Given this list of marker genes Uqcrc1, Uqcrfs1, Cyc1, Uqcr11, Uqcc3, Cycs, Uqcrq, mt-Cytb (NCBI Gene Id 17711), Cyct, Uqcr10, Uqcrc2, Uqcrh, Uqcrb, here is a description of the gene set: The transfer of electrons from ubiquinol to cytochrome c that occurs during oxidative phosphorylation, mediated by the multisubunit enzyme known as complex III. studied in species Mus musculus Mouse Gene Set: GOBP_MITOCHONDRIAL_ELECTRON_TRANSPORT_UBIQUINOL_TO_CYTOCHROME_C